Given this list of marker genes Grm8, Tas2r135, Tas2r106, Tas2r121, Gabbr1, Tas2r126, Tas1r1, Tas2r144, Tas2r108, Grm1, Tas1r2, Tas2r138, Tas1r3, Grm5, Grm7, Grm3, Grm4, Tas2r137, Tas2r120, Tas2r119, Tas2r140, Tas2r136 (taste receptor, type 2, member 136), Tas2r139 (NCBI Gene Id 353148), Casr, Gabbr2, Grm2, Tas2r131, Grm6, Tas2r118 (taste receptor, type 2, member 118), Tas2r130, Gprc6a, here is a description of the gene set: Class C/3 (Metabotropic glutamate/pheromone receptors) Mouse Gene Set: REACTOME_CLASS_C_3_METABOTROPIC_GLUTAMATE_PHEROMONE_RECEPTORS studied in species Mus musculus